The following is a description of a gene set: BCR activation is highly regulated and coreceptors like CD22 (SIGLEC2) set a signalling threshold to prevent aberrant immune response and autoimmune disease. CD22 is a glycoprotein found on the surface of B cells during restricted stages of development. CD22 is a member of the receptors of the sialic acid-binding Ig-like lectin (Siglec) family which binds specifically to the terminal sequence N-acetylneuraminic acid alpha(2-6) galactose (NeuAc-alpha(2-6)-Gal) present on many B-cell glycoproteins. CD22 has seven immunoglobulin (Ig)-like extracellular domains and a cytoplasmic tail containing six tyrosines, three of which belong to the inhibitory immunoreceptor tyrosine-based inhibition motifs (ITIMs) sequences. Upon BCR cross-linking CD22 is rapidly tyrosine phosphorylated by the tyrosine kinase Lyn, thereby recruiting and activating tyrosine phosphatase, SHP-1 and inhibiting calcium signalling. Reactome Pathway: CD22 mediated BCR regulation part of: Signaling by the B Cell Receptor (BCR) studied in species Homo sapiens, and this is the list of marker genes: IGHV1-46, LYN, IGLC2, IGHD, IGLV1-51, CD79A, IGKV2D-40, IGLV1-47, IGHV2-5, IGKV2D-28, IGKV1D-33, IGHV3-13 (immunoglobulin heavy variable 3-13), IGLV2-14, IGKV1-5, IGKV1-17, IGKV3-15, IGLV3-19, IGKV1-12, IGLV2-11, IGHV3-33, IGKV5-2, IGKV2D-30, IGKV2-29, IGKV1-16, IGHV3-53, IGLC3, IGKV1D-12, IGLV3-1, IGLV2-8, IGHV, IGHV3-48, IGLC7, IGHV4-39, IGLC6, IGHV3-7, IGHM, IGLV3-27, IGHV3-23, IGHV4-59, IGHV1-2, CD79B, IGLV3-21, IGHV3-9, IGKV4-1, IGHV2-70, IGHV3-11, PTPN6, IGKC, IGHV4-34, CD22, IGKV1D-16, IGLV7-43, IGLV, IGKV2-30, IGLV1-44, IGLV1-40, IGKV3-20, IGLV2-23, IGKV1-33, IGHV3-30, IGKV2-28, IGLV3-25, IGLV6-57, IGHV1-69, IGLC1, IGKV1D-39, IGKV1-39, IGHV7-81, IGKV3-11, IGKV3D-20